Given this list of marker genes Prelid1, Steap3, Zfp420, Triap1, here is a description of the gene set: electronically inferred by orthology from the curated human pathway studied in species Mus musculus This event has been computationally inferred from an event that has been demonstrated in another species.<p>The inference is based on the homology mapping from PANTHER. Briefly, reactions for which all involved PhysicalEntities (in input, output and catalyst) have a mapped orthologue/paralogue (for complexes at least 75% of components must have a mapping) are inferred to the other species. part of: TP53 Regulates Transcription of Cell Death Genes Reactome Pathway: TP53 Regulates Transcription of Genes Involved in Cytochrome C Release